Given this list of marker genes CDC27, GABRP, MTA1, PTGES3L, NFATC2 (NCBI Gene Id 4773), PECAM1, KCNK3, FAN1 (FANCD2 and FANCI associated nuclease 1), here is a description of the gene set: Genes predicted to be targets of miRBase v22 microRNA hsa-miR-10399-3p in miRDB v6.0 with MirTarget v4 prediction scores > 80 (high confidence targets). species: Homo sapiens Human Gene Set: MIR10399_3P from publication Chen Y, Wang X (PMID 31504780)